Given this list of marker genes GABRB1, GPR156, GABRR3, GABBR1, GABRA5, GABRA4, GABRB3, GABRE, GABRG2, GABRA1 (NCBI Gene Id 2554), GABRG1, GABRR2, GABRD, GABBR2, GABRB2, GABRA2, GABRQ, GABRR1, GABRG3, GABRP, GABRA3, GABRA6, GRID1, here is a description of the gene set: Combining with gamma-aminobutyric acid (GABA), and transmitting the signal from one side of the membrane to the other to initiate a change in cell activity. (GABA, 4-aminobutyrate) is an amino acid which acts as a neurotransmitter in some organisms. species: Homo sapiens Human Gene Set: GOMF_GABA_RECEPTOR_ACTIVITY